The following is a description of a gene set: studied in species Homo sapiens Reactome Pathway: Cell recruitment (pro-inflammatory response) Migration of immune cells is orchestrated by a fine balance of cytokine and chemokine responses. During Leishmania macrophage interaction, either pro inflammatory or anti-inflammatory cytokines are produced, having an impact in the establishment of infection and further clinical outcome. Toll like receptors, GPCRs such as the purinergic receptors P2YRs, complement receptor 3A and interleukin receptor 15 amongst others, have been associated with the production of pro inflammatory cytokines (Lai and Gallo 2012 & Cekic et al. 2016). A strong pro inflammatory response in the acute phase of the infection helps to control the parasite load when the recruited cells enhance microbiocidal mechanisms. However, alterations in the chemokine network may contribute to uncontrolled immune responses that can modulate parasite survival and promote or mitigate the associated immunopathology, thereby influencing the outcome of infection. part of: Leishmania infection, and this is the list of marker genes: NFKB2, IL1B, C3AR1, TXNIP, TXN, C3, APP, IL18 (interleukin 18), HSP90AB1, NT5E, NFKB1, CTSG, HMOX1, CASP1, P2RX7, SUGT1, NLRP3, IL1A, RELA, hly, ENTPD5, GSDMD, PYCARD, ENTPD1, P2RX4, MEFV, PSTPIP1